Given this list of marker genes CCR5, MFSD1, CRLF3, PCIF1, HMG20A, NRM, METTL14, ETFRF1, MTSS1, SH2D1B (SH2 domain containing 1B), RRAS2, DSE, HOPX, CAB39L, HYI, RPS6KA5, TGIF1 (NCBI Gene Id 91941), ZC3H10, STAP1, PXDC1, FCHSD1, NAAA, DUS2, GALNT11, TMEM229B, P2RY12 (purinergic receptor P2Y12), RAB19, NAPSA, BATF, SCAI, SAMTOR, GRB2, KRAS, EIF3F, ARHGDIB, ADNP2, SLAMF1, MYO1H, JTB, PEAK1, HIF1A, CCDC6, DDX54, ANKMY2, TCEA2, TMEM245, KATNIP, REEP3, ARHGEF3, PAIP2, PRKAB2, ARMC3, C19orf48P, BORCS7, MECP2, STX16, TMEM64, ANKRD16, OPTN, LIMD1, DENND4A, S100A11, COPG2, CD180, EMID1, CLCA2, SMAD2, VHL (von Hippel-Lindau tumor suppressor), RAB21, HCK, EXOSC7, TUSC3, RDH12 (retinol dehydrogenase 12), ZCCHC2, RPS9, AICDA, BCL7A, GEM, LONRF1, ARPC2, LCK, ID2 (NCBI Gene Id 3398), EEIG2, CDK9, C12orf57, NCOR1, EID1, EPOP, ELOVL1, PRR3, ZC3H12A, PAXBP1, EIF2AK4, AP1B1, SNAP29 (synaptosome associated protein 29), TMEFF1, TRIM34 (tripartite motif containing 34), INSR, LRPPRC, ARPC5, NAE1, UBE2D1, ATXN7L1, PPCDC, LFNG, RELL2, SLC35F6, GMIP, POLR1D, KCTD1 (NCBI Gene Id 284252), CAPZB, NPRL3, KANSL1, SLC20A2, KLF12, ASCC2, AHCTF1, SMC6, VPS13B, STX17, WDR41, TIGD2, HMGN3, KLF16, SNX9, GMFG, RASD1, IRAG2, TBCEL, TBC1D14, PRKAR1A, ABITRAM, PHTF2, CAMKMT, GSTT2, DKKL1, DTNBP1, SLC25A3, PHKG2, LCLAT1, POLR3B (NCBI Gene Id 55703), APBB1IP, EXTL1, DTNB, KRTCAP3, DCXR, NIPSNAP1, BID, GNGT2, FAM168B, VASP, FCRL1, SDHAF2, CHD9, TRAP1, SYNJ2, FTH1, RHOF, RP9, CORO1A, NSMCE1, RGS19, TXNDC16, CYB561A3, TOB2, AP1M2, ABHD5, WIPF1, SLC9A5, SETX, WDR1, CTPS2, KCNG1, MACIR, DAZAP2 (DAZ associated protein 2), BLTP1, RALGAPB, GAB3, TNNI2, RABEP1, DPP7, MUSTN1, DEXI, EVA1B, PRKX (NCBI Gene Id 5613), SNX29, SLC6A6, ZC3H12C (zinc finger CCCH-type containing 12C), TEN1, PAG1, ZNF512B, CHML, NFAT5, COMMD4, SAMD11, SNX2, LIME1, FAM120AOS, SBK1, here is a description of the gene set: studied in species Homo sapiens Genes down-regulated in CD4 T cells: untreated (0h) versus activated by anti-CD3 and anti-CD28 and then stimulated by TGFB1 and IL4 (2h). Human Gene Set: GSE2770_UNTREATED_VS_TGFB_AND_IL4_TREATED_ACT_CD4_TCELL_2H_DN from publication Lund R, Aittokallio T, Nevalainen O, Lahesmaa R (PMID 14607935) Th1 and Th2 cells arise from a common precursor cell in response to triggering through the TCR and cytokine receptors for IL-12 or IL-4. This leads to activation of complex signaling pathways, which are not known in detail. Disturbances in the balance between type 1 and type 2 responses can lead to certain immune-mediated diseases. Thus, it is important to understand how Th1 and Th2 cells are generated. To clarify the mechanisms as to how IL-12 and IL-4 induce Th1 and Th2 differentiation and how TGF-beta can inhibit this process, we have used oligonucleotide arrays to examine the early polarization of Th1 and Th2 cells in the presence and absence of TGF-beta after 0, 2, 6 and 48 hours of polarization.